Given this list of marker genes Slc22a1 (solute carrier family 22 (organic cation transporter), member 1), Slc25a33, Slc28a1, Slc22a2, Slc25a36, Slc28a3, Slc28a2b, Slc29a1, Slc29a3, Aqp9, Slc47a1 (solute carrier family 47, member 1), Slc19a3, Slc44a4, Slc25a19, Slc29a2 (NCBI Gene Id 13340), Slc19a2, Slc28a2, here is a description of the gene set: Mouse Gene Set: GOBP_PYRIMIDINE_CONTAINING_COMPOUND_TRANSMEMBRANE_TRANSPORT The process in which a pyrimidine-containing compound is transported across a membrane. A pyrimidine-containing compound is any compound that contains pyrimidine or a formal derivative thereof. studied in species Mus musculus